The following is a description of a gene set: Any process that results in a change in state or activity of a cell (in terms of movement, secretion, enzyme production, gene expression, etc.) as a result of the deprivation of oxygen and glucose. Mouse Gene Set: GOBP_CELLULAR_RESPONSE_TO_OXYGEN_GLUCOSE_DEPRIVATION studied in species Mus musculus, and this is the list of marker genes: Acvr2a, Becn1, Map1lc3a, Mapk8, Inhba, Dram1